The following is a description of a gene set: Genes down-regulated in naïve CD8 T cells compared to effector CD8 T cells at contraction phase (day 15 after LCMV-Armstrong infection). How and when memory T cells form during an immune response are long-standing questions. To better understand memory CD8 T cell development, a time course of gene expression and functional changes in antigen-specific T cells during viral infection was evaluated. The expression of many genes continued to change after viral clearance in accordance with changes in CD8 T cell functional properties. Even though memory cell precursors were present at the peak of the immune response, these cells did not display hallmark functional traits of memory T cells. However, these cells gradually acquired the memory cell qualities of self-renewal and rapid recall to antigen suggesting the model that antigen-specific CD8 T cells progressively differentiate into memory cells following viral infection. Human Gene Set: KAECH_NAIVE_VS_DAY15_EFF_CD8_TCELL_DN from publication Kaech SM, Hemby S, Kersh E, Ahmed R (PMID 12526810) species: Homo sapiens, and this is the list of marker genes: GZMM, TRAPPC1, DSTN, KCTD9, GSTM3, AQP9, EMP1, ZNF821, EEA1, PHF13, ANXA4, IL18R1, VMP1, LRP10 (NCBI Gene Id 26020), EFHD2, GALNT3, CASP4, RALY, ADORA2A, GMFG, ANXA1, NR4A2, CCL4, PRF1, IFNG, S100A4, MED12L, PGLYRP1, EMP3, SH2D1A, ITGAX, CASP3, CCR2, ELL2, CLDND1, POLR2L, FCGRT, MYADM, MAPRE2, RPAP1, CD47, TENM1, SMYD1, MAP7D1, GABARAPL2, FGL2, RSU1, MYO1F, SNX10, ARF6 (NCBI Gene Id 63379), GGH, RACGAP1, TMED10, UNC119B, ALCAM, INSM1, CTLA4, RAB33B, PRDM1, DOCK5, FCGR2B, PRDX1, ENTPD1, S100A13, GPM6B, ITGAL, STARD10, CASP7, DENND5A, KLRG1, RORA, ALAD, F2R, PRXL2A, KLRK1, RECK (NCBI Gene Id 8434), LYPLA2, ENPP1, KLRC1, STMP1, DNMT1, CXCR3, ID2, ITGB1, HASPIN, RRBP1, EOMES, DAPK2, GBP4, TXN, XDH, COPRS (NCBI Gene Id 95076), GZMB, RPA2, IFITM10, HOPX, TXNDC5, TERF1, PRDX4, GZMA, CMC2, CYP3A43 (cytochrome P450 family 3 subfamily A member 43), PLSCR1, MTM1, ANXA2, AHNAK (NCBI Gene Id 79026), SOCS2, HMGB2, TSPAN31, CHPT1, CCNB2, FAM89B, COX17, GLRX, LPIN2, CD4, CD160, BBLN, ETFB, S100A10, IL13RA2, CCR5, NRP1, CAPN2, H1-0, HK2, LGALS1, H2AX, RHOQ, IL10RA, IL18RAP, ITGA4 (integrin subunit alpha 4), BCL2L2, SLC25A53, CRTAM, ACOT7, FASLG, NUCB1, CARHSP1, KLF10, ACTB, PTPN13, PERP, KRTCAP2, LAPTM5, LGALS3, FGR, HLA-A, NBEAL2, SLA, SRGN, NT5E, BCL2A1, STMN1, SEC61G, LPIN1, CR1L, S100A6, ERRFI1, ST3GAL6, LAMC1, MTMR7 (myotubularin related protein 7), SLC35E4, CHL1, MAN2A1, KLRD1, ATF6, CCND3, UBE2K, PRR13, TTC7B, KCNJ8, CTSD, PON1, MDFIC, ALG2 (ALG2 alpha-1,3/1,6-mannosyltransferase), SERPINB9 (serpin family B member 9), CCL5, RAB5C, RNF19B, SORBS1, IDE, PTTG1, MX2, CASP1, DNAJC1, GZMK, SSPN, S100A11 (NCBI Gene Id 6282), CD44, BHLHE40, FANCM, ZNF398, LXN, LITAF, MBD2, SNTB2, GJA1, H1-2, YBX3